The following is a description of a gene set: studied in species Mus musculus Catalysis of the reaction: 1D-myo-inositol 1,3,4,5-tetrakisphosphate + H2O = 1D-myo-inositol 1,3,4-trisphosphate + phosphate. Mouse Gene Set: GOMF_INOSITOL_1_3_4_5_TETRAKISPHOSPHATE_5_PHOSPHATASE_ACTIVITY, and this is the list of marker genes: Inpp5k, Ocrl, Inpp5d, Inpp5j, Synj2